Given this list of marker genes TUBA1B, TUBB2A, TUBA1A, TUBB3, CDK5R1, CAPN2, TUBA3E, CDK5, MAPT, TUBB1, TUBB2B, APP, TUBB, TUBB6, TUBA8, TUBB4B, TUBB8 (NCBI Gene Id 347688), TUBB4A, TUBA4A, TUBA3D, CHRNA7, CAPN1, TUBA3C, TUBA1C, here is a description of the gene set: species: Homo sapiens Mutation-caused aberrant Abeta to anterograde axonal transport. Pathway ID: N01018. Pathway type: Variant. Pathway class: nt06460 Alzheimer disease. Human Gene Set: KEGG_MEDICUS_VARIANT_MUTATION_CAUSED_ABERRANT_ABETA_TO_ANTEROGRADE_AXONAL_TRANSPORT Pathway Definition from KEGG: APP* -> Abeta -> CHRNA7 -> Ca2+ -> CAPN -> CDK5R1 == CDK5 -> MAPT -| (TUBA+TUBB)